Given this list of marker genes Ntsr1, Cacna1a, Hrh3 (histamine receptor H3), Slc6a1 (solute carrier family 6 (neurotransmitter transporter, GABA), member 1), Htr6, Abat, Trpc4, Sv2a, Apba1, Htr1b, Pak1, Trh, Cacnb4, Gabbr1, Nf1, Best1, P2rx7, Htr1a, Grik1, Htr2c, here is a description of the gene set: species: Mus musculus Mouse Gene Set: GOBP_GAMMA_AMINOBUTYRIC_ACID_SECRETION The regulated release of gamma-aminobutyric acid by a cell or a tissue. The gamma-aminobutyric acid is the principal inhibitory neurotransmitter in the brain but is also found in several extraneural tissues.